Given this list of marker genes HES1, ITSN2, NKX2-1, SOX4, ADCY9, SEPTIN9, PLD3, CCND1, HHEX, NR4A1, DHRS3, EPOR, EVPL, ARHGAP1 (Rho GTPase activating protein 1), SRSF6, RUBCN, APLP2, SPRY1, PHIP, FBN1, LRP4, POMK, DYNC2LI1, AP1G2, SATB1, LASP1, MXRA7, BTG2, SLC35E2B, CHD4, ATP13A3, DEGS1, CEBPD, GOLGA8A, ANK3, MDK, MFSD10, CLASP1, DUSP6, ST3GAL5, SMARCC1, CDC25B, GAS6, FYN, SRSF11, IGSF1, ZC3H14, TNFRSF10B, BEX4, SFPQ, CTBP2, FOSB, here is a description of the gene set: Human Gene Set: LUI_THYROID_CANCER_CLUSTER_1 Cluster 1: genes with similar expression profiles across follicular thyrorid carcinoma (FTC) samples. The demonstration of the PAX8-PPAR(gamma) fusion oncogene in a subset of follicular thyroid tumors provides a new and promising starting point to dissect the molecular genetic events involved in the development of this tumor form. In the present study, we compared the gene expression profiles of follicular thyroid carcinomas (FTCs) bearing a PAX8-PPAR(gamma) fusion against FTCs that lack this fusion. Using unsupervised clustering and multidimensional scaling analyses, we show that FTCs possessing a PAX8-PPAR(gamma) fusion have a highly uniform and distinct gene expression signature that clearly distinguishes them from FTCs without the fusion. The PAX8-PPAR(gamma)(+) FTCs grouped in a defined cluster, where highly ranked genes were mostly associated with signal transduction, cell growth and translation control. Notably, a large number of ribosomal protein and translation-associated genes were concurrently underexpressed in the FTCs with the fusion. Taken together, our findings further support that follicular carcinomas with a PAX8-PPAR(gamma) rearrangement constitute a distinct biological entity. The current data represent one step to elucidate the molecular pathways in the development of FTCs with the specific PAX8-PPAR(gamma) fusion. species: Homo sapiens from publication Lui WO, Foukakis T, Lidén J, Thoppe SR, Dwight T, Höög A, Zedenius J, Wallin G, Reimers M, Larsson C (PMID 15608688)